The following is a description of a gene set: Mouse Gene Set: MIR_490_3P from publication Chen Y, Wang X (PMID 31504780) species: Mus musculus Genes predicted to be targets of miRBase v22 microRNA mmu_miR_490_3p in miRDB v6.0 with MirTarget v4 prediction scores > 80 (high confidence targets)., and this is the list of marker genes: Mctp1, Pi15, Pmp2, Ddx17, Mecp2, Arfgef1, Dipk2a, Rpl23, Usp9x, Ahctf1, Smap1, Slc8a3, Slc38a6, Arhgap32 (Rho GTPase activating protein 32), Smarcd1, Rfx7, Gli2, Rbpj, 1700019A02Rik, Akirin2, Rab14 (NCBI Gene Id 99047), Slc31a1, Ndufab1, Kmt2c, Ube2ql1, Magea8, Ell3, Atosa, Ube2r2, Mdga2, Cacna1h, Slain2, Pi4k2a, Zfp341, Rbm12, Eeig1, Rasal2, Sp4, Ppp4r2, Clec12b, Kdm7a, Nf1, Cdyl2